Given this list of marker genes IFIT1, IFI44, OASL, HEG1, PLA2G4A, HERC6, IFI44L, GPR35, IFIT3, HERC5, NRIP1, MX1, SLC12A8, RSAD2, here is a description of the gene set: Genes up-regulated in T lymphocytes overexpressing TERT off a retrovirus vector. studied in species Homo sapiens Little is known about the long-term consequences of overexpression of the human telomerase reverse transcriptase (hTERT) gene in T lymphocytes. To address this issue, we transduced polyclonal as well as clonally derived populations of naive and memory CD44 T cells from 2 healthy donors (aged 24 and 34 years) with retroviral vectors encoding green fluorescence protein (GFP) and hTERT (GFP-hTERT) or GFP alone. After transduction, cells were sorted on the basis of GFP expression and cultured in vitro until senescence. T cells transduced with hTERT exhibited high stable telomerase activity throughout the culture period. Relative to GFP controls, minor changes in overall gene expression were observed yet the proliferative lifespan of the hTERT-transduced populations was significantly increased and the rate of telomere loss was lower. Nevertheless, hTERT-transduced cells showed progressive telomere loss and had shorter telomeres at senescence than controls (2.3 +/- 0.3 kilobase versus 3.4 +/- 0.1 kb). Furthermore, a population of cells with 4N DNA consisting of binucleated cells with connected nuclei emerged in the hTERT-transduced cells prior to senescence. We conclude that overexpression of hTERT in CD4+ T cells provides a proliferative advantage independent of the average telomere length but does not prevent eventual genetic instability and replicative senescence. Human Gene Set: ROETH_TERT_TARGETS_UP from publication Röth A, Baerlocher GM, Schertzer M, Chavez E, Dührsen U, Lansdorp PM (PMID 15741219)